The following is a description of a gene set: Human Gene Set: HP_TENDON_RUPTURE Tendon rupture species: Homo sapiens Breakage (tear) of a tendon., and this is the list of marker genes: THBS2, HGD (NCBI Gene Id 727722), TTR (transthyretin), COL1A2, EMILIN1, IFIH1